Given this list of marker genes Abcg8, Abcd2, Abca6, Abca12, Abcg1, Abcd3, Abcd1, Abca5, Abcg5, Pex19, Apoa1, Abca3, Abcg4, Abca7, Abca9, Pex3, Abca2, here is a description of the gene set: ABC transporters in lipid homeostasis species: Mus musculus Mouse Gene Set: REACTOME_ABC_TRANSPORTERS_IN_LIPID_HOMEOSTASIS